Given this list of marker genes VWC2, HIPK2, TMPRSS6, BAMBI, MIR214, SKOR1, ERFE (NCBI Gene Id 151176), WNT1, MIR199B, FBN1, MIR885, CRIM1, SOST, NBL1, DKK1, VWC2L, SMAD6, DAND5, SKOR2, MIR195, SFRP2, PPARG, GDF3, CER1, MIR93, SKI, MIR302C, GREM1, TMEM53, CAV1, MIR210, DLX1, MIR199A1, LRP2, FZD1, CHRDL1, LEMD3, WNT5A, MIR26A1, MIR125B1, PPM1A, TRIM33, MICOS10-NBL1, CHRDL2 (NCBI Gene Id 25884), NOTCH1, CTDSPL2, MTMR4, SOSTDC1, SMURF2, SMURF1, HJV, SORL1, ABL1, TOB1, MIR98, CHRD, MIR20A, GREM2, TNFAIP6, HTRA3 (NCBI Gene Id 94031), UBE2D3, RBPMS2, NOG, UBE2D1, SFRP1, TWSG1, MIR100, GPR155, FSTL3 (NCBI Gene Id 10272), SPART, MIR106A (NCBI Gene Id 406899), SKIL, HTRA1, BMPER, SMAD7, here is a description of the gene set: species: Homo sapiens Any process that stops, prevents, or reduces the frequency, rate or extent of the BMP signaling pathway. Human Gene Set: GOBP_NEGATIVE_REGULATION_OF_BMP_SIGNALING_PATHWAY